The following is a description of a gene set: Genes up-regulated in CD40L and IL-2 IL-4 IL-5 stimulated at day 1 B cell IRF4-KO versus CD40L and IL-2 IL-4 IL-5 stimulated at day 3 B cell IRF4-KO. from publication Ochiai K, Maienschein-Cline M, Simonetti G, Chen J, Rosenthal R, Brink R, Chong AS, Klein U, Dinner AR, Singh H, Sciammas R (PMID 23684984) species: Homo sapiens Human Gene Set: GSE46606_DAY1_VS_DAY3_CD40L_IL2_IL5_STIMULATED_IRF4_KO_BCELL_UP Temporal analysis of B cell activation in vitro using CD40L and IL-2/4/5 cytokines in wild type Irf4+/+ B cells or in mutant Irf4-/- B cells harboring a tet-inducible allele of Irf4. IRF4 expression was restored, or not, in the Irf4-/- background by culturing in the presence of low or high concentrations of doxycycline. The results provide insight in the role of IRF4 expression levels in coordinating different programs of B cell differentiation., and this is the list of marker genes: C2CD2L, CX3CL1, KLHL4, RHBDL1, NUTM1, LMBR1L, CTSH, STX8, AGAP2 (ArfGAP with GTPase domain, ankyrin repeat and PH domain 2), PRR12, FGF7, ERAL1, SPAG4, SLC25A18, GALE (UDP-galactose-4-epimerase), PCDH18, COL8A2, SSBP4, NOTCH4, TMEM200A, CNTNAP1, NFYC (nuclear transcription factor Y subunit gamma), CCNL2, NR1H2, ARPC3, SLC38A5, SLC16A8, AKNAD1, POMGNT1 (NCBI Gene Id 55624), GPS2, TVP23A, SPATA33, CACNA1H, UCP3, LRP1, UBE2M, ZNF580, RDH14, PROX2, CIC, SDK1, SIRT6, PNOC, GALR3, IGDCC3, MNX1, CST11, PRSS45P, DGKH, EVC, TMEM185A, VPS72, ANTXR1, EFNB2 (ephrin B2), NDUFS8, CCDC137, TET3, LRRN1, SCGB1A1, SORBS3, BOLA2, NCDN, KIAA1549, NFE2L3, KRT31, ZFYVE1, SSR1, ZIC2, OLFM3, CIAO3, SCAMP5, SUB1, FBXO24 (F-box protein 24), TNNT2, RIMS4, C19orf67, CELF6, COX6B1, ACOT2, DUSP26, TLR5, NECAP2, C1QTNF4, TP53, CFAP52, SNAPC2, NHSL2, FBF1, CLASRP, ALG10, PCCB, MYF6 (NCBI Gene Id 4618), MTFR1L, OLFML1, LTC4S, CHCT1, ARHGAP32, CCDC62 (NCBI Gene Id 84660), CFB, ENTREP2, HTR1D, PCDHB12, OCIAD1, KRT14, HYAL3, ZFPM1, FMNL3, OPTC, PUDP, UNC93B1, COL24A1, EPB41L4A, RAB43, UXS1, TTC39A, SLC26A10P, KIF14, MMP9, KRTAP4-12, MEP1A, ENTR1, PIGK, PTCRA, BDKRB2, GFRA2, TREH, GPI, RIMKLA, RWDD4, BOLL, FAM120B, SUN3, DSC1, TRMU (NCBI Gene Id 55687), CDK9, OSCAR, CNN1 (calponin 1), MZF1, DDAH1, GTDC1, CAMSAP1, THBS1, OMG, FSCN2 (fascin actin-bundling protein 2, retinal), CCL2, NR2E3, ZDHHC23, PHF21B, ABCG4, KRT18, EDAR, PRRX2, TMEM98, DUSP28, NADSYN1, LIPT1, TRIM65, MINDY4, BMI1, B3GLCT, PALD1, ANKRD34B, RAB40C, PSMC5, AGGF1, TFAP2E, HSD17B7, ZNF687, CDKAL1, DAB1, NLRP10, RLF, SOBP, ELP2, SRF, ELOVL1, LAMTOR1, TRMT44, VPS37C, P4HA3, TRAIP, NPHP3, CTNNA2, DLK1, LYZL1 (lysozyme like 1), CALML3, OBP2B, ATOH7, MUC13, PSMD14, SLC29A2, DLX6, CRTAC1 (cartilage acidic protein 1), APOBEC2, TRAPPC9, CACNG8, MAB21L2, UNC5D, USP5, DDX3Y